The following is a description of a gene set: Human Gene Set: GOBP_NEUROMUSCULAR_JUNCTION_DEVELOPMENT A process that is carried out at the cellular level which results in the assembly, arrangement of constituent parts, or disassembly of a neuromuscular junction. species: Homo sapiens, and this is the list of marker genes: CACNG2, LRRK2 (leucine rich repeat kinase 2), PDZRN3, CNTNAP1, ETV5, F2R, COL4A1, CACNB4, NEDD4L, LIN7B, NEDD4 (NEDD4 E3 ubiquitin protein ligase), GPHN, PPFIBP2, SPG11, LIN7A, SPTBN4, CACNB2 (calcium voltage-gated channel auxiliary subunit beta 2), COL4A5, LAMB2, CACNA2D2, DNAJA3, DCTN1, CACNA1S, MESD, RER1, PPFIBP1, CHRNA1, CRKL, AFG3L2, SIX1, FARP1, DOK7, FNTA, KY, ALS2, TNC, ZC4H2, COLQ, LARGE1, SLC18A3, DVL1, MUSK, SIX4, ANK3, P2RX2, LRP4 (LDL receptor related protein 4), RAC1, RAPSN, CRK, PDZD11, MYCBP2, LIN7C, FZD9, KCNJ8, AGRN, ERBB2